Given this list of marker genes Tbxas1 (NCBI Gene Id 21391), Cox17, Msr1, Tpm4, Sdc4, Eef1e1, Alcam, Tmed2, Sec61b, Mrpl19 (mitochondrial ribosomal protein L19), Sidt2, Ldha, Eprs1, Zfp706, Yif1a, Eif4a1, Rpf2, Pilra, Cox5a, Lman1, Tmem11, Nolc1, Ctsz, Bcl2a1d, Agps, Amfr, Adora2b, Rpn2, Ran, Eif4g2, Macroh2a1, Nme1, Uchl3, S100a10 (NCBI Gene Id 99776), Ibtk, Enah, Spp1, Sarnp, Snrpa, Bhlhe40, Calm1, Cyb5b, Fkbp1a, Mycbp2, Agpat5, Ssb, Elovl1, Bccip, Rexo2, Qrsl1, Tarm1, Tmem30a, Srgn, Ccr5, Ndufb6, Ppie, Chil3, Twf2, Srm, Timm10, Bcl2a1a, Tmem126a (NCBI Gene Id 66271), Far1, Znhit1, Rbm25, Cmklr1, Ppa1, Hdgf, Azin1, Cd300lf, H2-DMb2, Tcerg1, Imp4, Ffar2, Vps29 (VPS29 retromer complex component), Hnrnpa1, Psmb4 (NCBI Gene Id 19172), Bak1, Pfkp, Cish, App, Magt1, Cggbp1, Arpc1b, Eif3a, Eif2s1, Farsb, Cdh1, Naa15, Lgmn, Smyd5, Zfp593, Srgap2, Serp1, Nus1 (NUS1 dehydrodolichyl diphosphate synthase subunit), St6galnac4, Samm50, Itgam, Eif4e, Atp5mc1, Clns1a, Cct8, Ppia, St13, Cfl1, Hspd1, Idh2, Arhgap31, Sf3b3, Bcl2a1b, Snrnp40, Mrpl36, Pgk1, Gar1 (GAR1 ribonucleoprotein), Sav1, Ddx39a, Ostc, Psmb3, Bnip2, Wdr12, Eif2s3x, Commd7, Glipr2, Cstb, Bag1, Eno1, B4galnt1, Tomm40, Lgals1, Pfn1, Pet100, Tlr2, Ost4 (NCBI Gene Id 67695), Ddx21, Dad1, Cox7b, U2af2, Serbp1, Tagln2, Dhx36, Micos10, Atp6v0a1, Slc35b1, Eps8, Sh3bgrl, Capg, Snx2, G3bp1, Ube2m, Rxra, Dok2, P4hb, Znrd2, Erg28, St7 (suppression of tumorigenicity 7), Clec4n, Nhp2, Fabp5, Hnrnpf, Srsf2, Ybx3, Tcp1, Naa20, Timm13, Tmem37, Socs3, Ranbp1, Rbpj, Snrpa1, Pdia4, Eef1g, Morf4l2, Tsfm, Slc29a3, Lilrb4b, Scimp, Sulf2, Tomm22, Dynll1, Banf1, Ruvbl1, Ipo5, Aimp2, Cd44, Atp5f1a, Anxa2, Cycs, Tes, Cmpk1 (NCBI Gene Id 66588), Pdia6, Calr, Gapt, Hspa9, Stxbp3, Cnbp, Mettl16, Timm9, Cd24a, Eif4e2, Ppp4r2, Prkcd, Orai1, Tgfb1, Set, Rnf126, Spcs2, Tmed9, Nudc, Pkm, Ralb, Vrk1, Batf3, Psmg3, Rrp15, Hnrnpa0, Hsp90b1, Tuba1b, Rsl1d1, S100a4, Hnrnpa3, Prpf31, Ndufa12, Sfxn1, Ybx1, Stx7, Cast, Mrpl35, Fam3c, Mybbp1a, Bzw1, Hsd17b12, Gas7, Klhdc4, Fbl, Septin11, Srsf9, Stt3b, Rbx1, Ms4a6d, Hspe1, Dmkn, Rasgrp1, H13 (histocompatibility 13), Magoh, Creld2, Runx1, Eef1akmt4, Nsfl1c, Spint1, Pdap1, Gpatch4, Txnl4a, Chchd2, St3gal1, Srsf3, Cfp, Nop16 (NCBI Gene Id 28126), Psmg1, Uck2 (NCBI Gene Id 98564), Ppp1r14b, H2-DMb1, Irf2bp2, Atxn2l, Abce1, Dab2, Ciita, Atf1, Cdkn1a (cyclin dependent kinase inhibitor 1A), Polr2f (polymerase (RNA) II (DNA directed) polypeptide F), Mydgf, Ssr1, Zranb2 (zinc finger, RAN-binding domain containing 2), Mapkapk3, Ndufb2, Txndc9, Snrpd1, Mrpl55, Snrpf, Mrto4, Tnfrsf13b, Sec13, Ccl24, Pusl1, Tpm3, Cct3, Tfec, Timm8a1, Mettl1, Ccdc88a, Pilrb2, Dpagt1, Llph, Hnrnpab, Atp5f1b, Pomp, Snx3, Cops5, Fgd2, Lsm12 (NCBI Gene Id 68741), Mdh2, H2-DMa, Qpct, Nucb1, Cox7a2, Mrpl12, Tmem65, Syncrip, Mtss1, Praf2, Cox8a, Slc11a1, Reep3, Eif2b1, Rer1, Ezr, Rpn1, Bax, Pilrb1, Srsf7, Lmna, Ankrd13c, Hnrnpu, Hnrnpm, Pa2g4, Mrps18b, Gapdh, Xbp1, Shtn1, Cd164, BC031181, Pebp1, Ltb4r1, Nars1, Jkamp, Adprh, Naaa, Arl1, Fcgr2b, Rab35, Idi1, Vim, Cct5 (chaperonin containing TCP1 subunit 5), Ank, Vcan, Nsun2, Klrb1f, Myl12a, Cuedc2, Lta4h, Ncl, Erh, Vasp, F10, Eif5a, Smad7, Commd2, Vapa, Polr2m, Bop1, Pim1 (proviral integration site 1), Anp32b, Ebna1bp2, Ngly1, Jaml, Ssr2, C3ar1, Krtcap2, Rrp9, Fcgr3, S100a6, Denr, Emilin2, Gclm, Fam162a, Psmd14, Mrps15, Plaur, Glrx5, Tiam1, Hs3st3b1, Coro2a, Idh3a, Grwd1, Rab44, Cndp2, Sec11a, here is a description of the gene set: Mouse Gene Set: CUI_MONOCYTE_GM_CSF_RESPONSE_UP Cytokines mediate cell-cell communication in the immune system and represent important therapeutic targets. A myriad of studies have highlighted their central role in immune function, yet we lack a global view of the cellular responses of each immune cell type to each cytokine. To address this gap, the authors created the Immune Dictionary, a compendium of single-cell transcriptomic profiles of more than 17 immune cell types in response to each of 86 cytokines (>1,400 cytokine-cell type combinations) in mouse lymph nodes in vivo. A cytokine-centric view of the dictionary revealed that most cytokines induce highly cell-type-specific responses. For example, the inflammatory cytokine interleukin-1β induces distinct gene programmes in almost every cell type. A cell-type-centric view of the dictionary identified more than 66 cytokine-driven cellular polarization states across immune cell types, including previously uncharacterized states such as an interleukin-18-induced polyfunctional natural killer cell state. Genes positively differentially expressed in cell type: Monocyte upon treatment with cytokine: GM-CSF in mouse lymph nodes in vivo. from publication Cui A, Huang T, Li S, Ma A, Pérez JL, Sander C, Keskin DB, Wu CJ, Fraenkel E, Hacohen N (PMID 38057668) studied in species Mus musculus